The following is a description of a gene set: Enables the transfer of betaine from one side of a membrane to the other. Betaine is the N-trimethyl derivative of an amino acid. studied in species Mus musculus Mouse Gene Set: GOMF_AMINO_ACID_BETAINE_TRANSMEMBRANE_TRANSPORTER_ACTIVITY, and this is the list of marker genes: Slc22a21, Slc22a4, Slc22a5, Slc22a15, Slc6a20a